The following is a description of a gene set: species: Homo sapiens Any process that results in a change in state or activity of a cell (in terms of movement, secretion, enzyme production, gene expression, etc.) as a result of a dexamethasone stimulus. Human Gene Set: GOBP_CELLULAR_RESPONSE_TO_DEXAMETHASONE_STIMULUS, and this is the list of marker genes: ERRFI1, ABCB1, METTL21C (methyltransferase 21C, AARS1 lysine), TFAP4, MSTN, AXIN2, PCK1, NR3C1, ASS1, SERPINF1, CRH, USP8, SRD5A1, TBX2, FECH, TGFB1, RPS6KB1, AQP1, ATP5F1A, CASP9, FBXO32, PCK2, CFLAR (CASP8 and FADD like apoptosis regulator), BMI1, CBX3, JAK2, DDIT4, EIF4E, SMYD3